Given this list of marker genes SPATC1L, PRKAR2B, PRKAR1B, LPAR1, SCT, ADRB2, RAMP3, ADIPOQ, PDE3A, CALCR, PRKAR1A, LRRK2, SESN2, CRH, IAPP, PRKAR2A, NPY2R, UCN, PDE4A, MIF, MC1R, APP, ADCYAP1R1, AKAP6, PDE10A, PKIA, here is a description of the gene set: Human Gene Set: GOBP_REGULATION_OF_CAMP_PKA_SIGNAL_TRANSDUCTION Any process that modulates the frequency, rate or extent of cAMP/PKA signal transduction. species: Homo sapiens